Given this list of marker genes GPR101, AIP, ATP6V0A2, ERCC6, KRAS, MTOR, PRKD1, PIGQ, HRAS, ASXL1, CREBBP, KCNH1, ATP6V1B2, HNRNPK, EP300, PIGN, KCNJ8, ABCC9, TBL1XR1, FBXO11, KCNN3, here is a description of the gene set: Deep plantar creases studied in species Homo sapiens Human Gene Set: HP_DEEP_PLANTAR_CREASES The presence of unusually deep creases (ridges/wrinkles) on the skin of sole of foot.